The following is a description of a gene set: Human Gene Set: HP_ABNORMALITY_OF_PATTERN_VISUAL_EVOKED_POTENTIALS species: Homo sapiens Abnormality of pattern visual evoked potentials, and this is the list of marker genes: DNM1L, OPA1 (OPA1 mitochondrial dynamin like GTPase), CWC27, CLN8, SPG11